The following is a description of a gene set: Ub-specific processing proteases (USPs) are the largest of the DUB families with more than 50 members in humans. The USP catalytic domain varies considerably in size and consists of six conserved motifs with N- or C-terminal extensions and insertions occurring between the conserved motifs. Two highly conserved regions comprise the catalytic triad, the Cys-box (Cys) and His-box (His and Asp/Asn). They recognize their substrates by interactions of the variable regions with the substrate protein directly, or via scaffolds or adapters in multiprotein complexes. part of: Deubiquitination studied in species Homo sapiens Reactome Pathway: Ub-specific processing proteases, and this is the list of marker genes: PSMD8, USP30, USP48, USP9X, H2BC14 (NCBI Gene Id 8342), USP17L11, USP20, H2AC6, PSMC5, USP17L13, RHOT1, ADRM1, USP11 (NCBI Gene Id 8237), USP13, MUL1, RIPK1, SMURF2, RNF146, USP21, VDAC1, PSMC3, NFKBIA, USP47, PTRH2, H2BC15, USP17L12, PSMB7, PSMA2, MDM2, PSMA4, USP19, USP4, PSMA5, H2BC12, SMAD7, PSMC4, WDR48 (NCBI Gene Id 57599), PSMB3, H2BC18, TP53, USP3, USP17L17, CLSPN, BIRC2, AR, H2AC1, AXIN2, USP34, IKBKG, SMAD3, SEM1, H2AC7, FOXO4, TNKS2, SUDS3, CCP110, PSMB2, GATA3, H2BC11 (H2B clustered histone 11), H2AC12, WDR20, BECN1, H2AC14, USP17L21, TOMM70, MDM4, ADRB2, MAP3K7, HIF1A, H2BC9, USP17L19, MYC, UBC, USP15, KAT2A, USP33, CYLD, PSMD2, CCNA1, USP17L3, H2AC11, RIGI, AXIN1, PSMC6, FKBP8, USP28, SIAH2, PSMD13, TADA3, UFD1, TRAF6, USP17L22 (ubiquitin specific peptidase 17 like family member 22), PSMA3, USP44, IFIH1, BIRC3, USP16, SKP2, H2BC4, CFTR, USP17L1 (NCBI Gene Id 401447), USP26, H2AC20, DDB2, TRRAP, PSMA7, CCNA2, PSMB1, CDC25A, H2AC25, USP17L24, PSMB6, H2BC13, USP24, VDAC2, USP17L2, PSMD7, USP49, H2BC1, PSMD1, USP17L10, USP25, TADA2B, VDAC3, TNKS, PSMC2, H2AC4, USP10, RNF128, USP8, IL33, H2BC26, PSMB5, PSMC1, USP5, ARRB1, MAT2B, USP17L4, USP14, ATXN7, USP17L15, PSMA1, STAM2, SNX3, SMAD1, TAF9B, USP37, RNF123, USP18, OTUB1, PSMD12, USP7, RPS27A, USP42, TGFBR1, HGS, IDE, SMAD2, PTEN, SMAD4, CDC20, TRAF2, PSMB4, USP17L20, USP17L5, TAB1, ARRB2, RCE1, UBA52, USP22, PSMD14, KEAP1, TOMM20, H2BC17 (NCBI Gene Id 8348), H2BC21, PSMD3, USP17L8, H2AC18, PSMD11, POLB, RUVBL1, TAF10, USP2, USP12, H2AC21, H2BC5, PSMA6, PSMD6, USP17L18, H2BC3, UBB